The following is a description of a gene set: Mouse Gene Set: GOBP_RESPONSE_TO_ELECTRICAL_STIMULUS studied in species Mus musculus Any process that results in a change in state or activity of a cell or an organism (in terms of movement, secretion, enzyme production, gene expression, etc.) as a result of an electrical stimulus., and this is the list of marker genes: Nsmf, Disc1, Rps6kb1, Crhr1, mt-Co1, Tacr1, Epo, Pten, Th, Hnrnpd, Myo6 (myosin VI), Fbxo32, Prickle2, Sod2, Btg2, Calr, Cyfip1, Adss2, Rest, Xbp1, Nr4a1, Gjb6, Myog, Gria1, Ntrk1, Trim63, Kcnj3, Atp1a3, P2rx7, Mstn, Cdk2, Musk, Prickle1, Ghrl, Src, Cd14, Tacr2, Nrf1, Gnat1, Brd1, Rab3a, Neurod2, Palm, Slc9a1, Grm1, Hpca, Akap12, Actb, Fzd3, Oxt, Ciita, Nqo1, Mmp2